Given this list of marker genes KDM3A, DNAJC13, COPS6, FGR, RAB31, GRHPR (NCBI Gene Id 9380), EDEM1, BUD31, CAMK1, HS6ST1, S100A12, FURIN, ITGAL, HK3, SH2B2 (NCBI Gene Id 10603), SRM, HLA-DQA1, PLAAT4, CLPP, S100A8 (S100 calcium binding protein A8, NCBI Gene Id 6279), LILRA3, ANKS1A, LMO4, MRPS12, NPY, SART1, HDLBP, HCAR3, ATP5PD, MT1F, MXRA7, ABCG1, PTPN22, SFTPC, EBP, FCGR1A, IFNA14, ATP5MC1, ARHGDIB, PDE6D, ELK4, LRP10, PSMB6, GPX2, ITGB2 (NCBI Gene Id 3689), FLOT1, TWF2, CDK14, SFXN3, IRX3, IKBKE, STOML2 (stomatin like 2), LCE2B, VAMP5, S100A9, RAB6A, FCN1, DRG1, ITPR1, KBTBD11, ATF4, MFSD5 (NCBI Gene Id 84975), RGS16, ERCC1, DUSP1, MIF, NDUFS2, UMOD, CAPNS1, PSMB10, PSMB3, CXCR4, FOXA2, POLR2I, P2RY6, RPN2, PLOD3, TMCC1, CD52, MAPK8IP2, RABGGTA, TSC22D4, SLC20A2, AURKC, MT1A, CTSH, HLA-DRB4, KCTD17, NDUFB8, GIGYF2, APOBEC3B, FADS1, IER2, LYL1, CORO1A, SLC16A3, SPARC, TAPBP, PPP1CA, SLC2A3, FOS, FOSB, LAGE3, PDGFB, UQCRQ, TSPO, COX6B1, HYAL2, TXNIP, SEC14L1, IRF7, ENPP2, NUDC, FADS2, MMP9, YARS1, CCNH, ATOSB (NCBI Gene Id 80256), CTPS1, DYNLT1, HLA-DQB1, HSPB1, GOT1, CLDN7, LSM2, IFNA1, KLHL21, VWA8, MYCBP, RRAS, ZFAND5, ASGR2, COX5B, DHPS, RUNX1T1, STIP1, COX8A, PTPA, RXRA, EXTL3, ST3GAL5, C2, RCC1, NBEAL2, YIPF1, CCL22, FCGR3A, SNHG29, AIM2, BCKDHA, MT1G, MVP, FBP1, NR4A2, SPN, PRIM2, DNAJB2, COL19A1, PGD, SUPT4H1, PURA, CSK, LY75, NRGN, PARVB, NUP210, RRP12, CAPG (capping actin protein, gelsolin like), SLC6A12 (NCBI Gene Id 6539), LGALS3BP, SLC7A7, FH, SLC34A1, AIMP2, OS9, RSAD2, CNPPD1, IL17RA, FGL2, CYP4A11, PCK2, FBL (NCBI Gene Id 2091), RAC2, TRIP6, SERPINA1, TGM2, LRRC42, IL2RG, LTA4H, DDIT4, BTN3A3, PTPN6, JUND, CENPB, TCIRG1, ARF3, MT2A, HBEGF, PAK1, IMPDH1, here is a description of the gene set: Human Gene Set: GSE19401_UNSTIM_VS_RETINOIC_ACID_STIM_FOLLICULAR_DC_UP studied in species Homo sapiens Genes up-regulated in the in vitro follicular dendritic cells from peripheral lymph nodes: non-stimulated versus tretinoin (96h). from publication Suzuki K, Maruya M, Kawamoto S, Sitnik K, Kitamura H, Agace WW, Fagarasan S (PMID 20643338) Germinal centers (GCs) are clusters of activated B cells built on stromal cells known as follicular dendritic cells (FDCs). In the Peyer’s patches (PPs), GCs are chronically induced by bacteria and are the major sites for generation of gut IgA immune responses. Whether FDCs directly contribute to the IgA production in PP GCs is unknown. To investigate the role FDCs in gut immune system, we examined comprehensive gene profiles of FDCs purified from PPs or perypheral lymph nodes (pLNs) with or without immunization. We also tried to reconstitute the PP FDC signature in vitro by pulsed or continuous stimulation of pLN FDCs through TLRs, RARs or simultaneously through TLRs and RARs.